The following is a description of a gene set: Mouse Gene Set: GOBP_REGULATION_OF_HEART_MORPHOGENESIS Any process that modulates the frequency, rate or extent of heart morphogenesis. species: Mus musculus, and this is the list of marker genes: Bmp2, Smo, Rbpj, Bmp4, Robo2, Robo1, Dkk1, Gata5, Mesp1